The following is a description of a gene set: Human Gene Set: GOBP_DENDRITIC_CELL_ANTIGEN_PROCESSING_AND_PRESENTATION The process in which a dendritic cell expresses antigen (peptide or lipid) on its cell surface in association with an MHC protein complex. studied in species Homo sapiens, and this is the list of marker genes: HLA-DRB3 (NCBI Gene Id 3125), CCL21, FGL2, HLA-DRA, MPEG1, FCGR2B, CCR7 (C-C motif chemokine receptor 7), NOD1, SLC11A1, CD68, HLA-DRB1, NOD2, THBS1, CCL19, CD74, CLEC4A